The following is a description of a gene set: Human Gene Set: MIR6733_5P from publication Chen Y, Wang X (PMID 31504780) Genes predicted to be targets of miRBase v22 microRNA hsa-miR-6733-5p in miRDB v6.0 with MirTarget v4 prediction scores > 80 (high confidence targets). species: Homo sapiens, and this is the list of marker genes: RGS8 (NCBI Gene Id 85397), CLASP2, TIGAR, KLHL3, FAM234B, ACSL5, NALCN, FRA10AC1, SNRK (SNF related kinase), RAVER2, ENTPD4, EVC, FILIP1, TMEM164, DLG3, MBOAT7, STRN4, KSR2, RAD54L2, ABCC1, CDK5, HSPB6 (NCBI Gene Id 126393), ZDHHC21, C9orf72, TESK2, MEGF8, KLF14, TERF1, RAB33A, ADGRL1, ARCN1, ZDHHC18, ARHGAP36, AMMECR1, ZBTB20, HDGFL3, GSTT2B, VANGL2, HLA-DQA1, NSD1, STYX, F5, FAM120A, PARP15, BEND3, ZNF3, CXCL12, BLTP3A, GSPT1, XBP1, ADPRHL1, TRIM47, TRABD2B, RAET1E (NCBI Gene Id 135250), KNSTRN, TOB2, ZBTB4, MARK1 (microtubule affinity regulating kinase 1), SRRM4, NR3C1, TNFAIP1, GMNC, PRX, ZMYM3, OPN3, SNX27, RPH3A, SHISAL1, SLC7A14, PKD2, ERGIC1, LZTS3, EPM2AIP1, WDR43, ATP6V1G2, MYCL, SPICE1, TMOD2, MAPRE2, NCBP3, VTCN1, MEP1A, ZNF704, IGF1, PLCD4 (NCBI Gene Id 84812), SNX11, SH3D19, CADM1, ANKRD17, FGF18, PTN, MMD, ACER2 (alkaline ceramidase 2), TTC9, BCL9, AFF2, TMEM217, SEMA3G, PBX2, TACC1, ZKSCAN7, VCL, SPOCK3, C1orf198, TMPRSS13, FBXO4, HAO1, TIGD3, DSCAM, GAS7, RABGAP1, RPP14, GUCY1A2, MAT1A, AGO3, GOLPH3, MCM10, PLS3, PIGN, PLA1A, DPF2, MECP2, ANKS1A, DCAF16, GKN2, PPIP5K2, SLC4A8, CGN, PCGF3, DLC1, BTN3A3, LIPA, DNAJC6, EBF3, WDR5B, C6orf89, KPNA3, MAPK8, SLC18A1, GLYATL3, GRM5, SHPRH, PFN2, CACNA1E, CTNNA3, KLF8, TMEM185B, EPN1, ATP1B1, MIF4GD, GPC6, ADNP, SELENOI, PSTPIP2, SCUBE2, THSD7A, NUDC, AAK1, RND3, KRBA1, FKBP5, ZNF84, YIPF5, ZBTB9, LYN, EFR3B, TTI2, SLC13A5, ATL2, TNIK, NEUROD1, PLEKHS1, FAR2, FECH, APOOL, SHTN1, RNF175, EPS8L3 (EPS8 signaling adaptor L3), CLASP1, POU3F4, GEMIN8, ERBB3, ASTN1, ATXN2L, VPS25, TAP2, ARFGEF3, LOX, KIF21B, SUOX, RBM4B, EFNA5, UCMA, PDK3, PAPPA, LANCL1, ADAM23 (ADAM metallopeptidase domain 23), YWHAZ, LMBRD2, MEX3C, ASCC3, DGKH (diacylglycerol kinase eta), HSPA9, FMO1, NOVA2, CHTF8, KMT2A, MCTP1, CDCA3, PRKAB2, SH3KBP1, PFKFB2, RAB8B, CCDC30, FNDC3A, CEP15, GRM6, TMEFF2, ST3GAL1, COLGALT2, SULT1C4, NFIA, RAB5B, AAMP, YWHAG, CLEC7A, SENP1, TSC1, PREX2, BRPF1, MARCHF4, BRPF3, NOTCH2NLA, KLHDC10, GORASP1 (golgi reassembly stacking protein 1), RTL5, ZBTB43, MARVELD3, ACP7, IPPK, FOXN1, HMGN5, OSBP, MIA3, PPM1L, NCAN, NPAS3, FAXC, LRRC51, CDH11, HERC3, RICTOR, CHD3, USP46, RAPGEF6 (Rap guanine nucleotide exchange factor 6), CREBL2, SMIM12, CXCL14, LINC02897, ANTXR1, ZNF326 (zinc finger protein 326), TGFBR1, STRADA, GPRASP3, KCMF1, ZDHHC9, PCDH12, TDRKH, RORA, RC3H1, SAMD10, WDR26, ZEB2, RIMOC1, ATP8B4, ABHD13